Given this list of marker genes FRS2, FGF10 (NCBI Gene Id 2255), FGF1, KL, FGF20, FGF9, PIK3CA, FGF8, FGF6 (NCBI Gene Id 2251), GRB2, GAB1, FGF5, FGF17, PIK3R1, FGF4, FGF2, FGF23, PTPN11, FGF3, FGF22, FGFR1, here is a description of the gene set: Human Gene Set: REACTOME_PI_3K_CASCADE_FGFR1 species: Homo sapiens PI-3K cascade:FGFR1